The following is a description of a gene set: The process in which the cochlea is generated and organized. Human Gene Set: GOBP_COCHLEA_MORPHOGENESIS studied in species Homo sapiens, and this is the list of marker genes: TBX2, HOXA1, SOX9, MYO3B, DCANP1, TBX1, POU3F4, GRHL3, TIFAB, MYO3A, DVL2, CTHRC1, FRZB, DVL1, VANGL2, TBX18, RAC1, PAX2, NEUROG1, WNT5A, HPN, SIX1, NECTIN3, ZEB1, EYA1, NECTIN1, FZD2, PTK7